Given this list of marker genes PSD4 (NCBI Gene Id 23550), CDC45, CRIM1, ARAP3, PTGFRN, NCKAP5, CPNE1, MYBPC2, DDOST, PSMB2, HNRNPA1, ROCK1, ZEB2, DUSP2 (NCBI Gene Id 1844), UFD1, ST18, NYAP1, GSE1, TNS2, MRPS18B, RDH10, TAGLN, RORA, SH3KBP1, TSPOAP1, SERTAD3, SPOP, SHC1, RASAL1 (NCBI Gene Id 8437), AUP1, JAKMIP2, LEFTY2, PDGFB, PHF12, ATP6V1E2, SKIDA1, HOXB1, KMT2E, SLC8A3, CHRM1, CNIH2, LINC01138, MEX3B, TSSK3, TINAGL1, RHOG, ELK3, CSRNP2, RPRD2, NSD1, MYL6B, INTS13, IL1RAPL1, FHL3, GDNF, EIF4E, CEP57, TPR, GARNL3, SMYD2, NDUFS4, CACNG6, PSMB1, BCL2, SLC4A2, PAFAH2 (NCBI Gene Id 5051), RHCE, RGL2, LAMB3, PRMT3, SERPINB5, RBM12, MAGED2, DCHS1, DMXL1, BMP4, HPX, RPS14, SKAP1, BCOR (NCBI Gene Id 57686), UBE4B, MIR22HG, POLD4, RPP21 (NCBI Gene Id 95307), S1PR1, DYNC1I1, PHC1, GPR3, THADA, H3-3B, SEMA4A, AJUBA, PTCH1, SGCD, KCNC1, CNOT4, SPTAN1, LCOR, TSPAN18, ZNF462, SRRM1, ELAVL2, IGF2BP3, GRIN2D, GTF2A1, CHRNB2, DDX17, NXPH4, SLC26A9, SOX21, SNX12, FGFR1OP2, ADCY8, ZNF532, HTRA2, NCDN, TARBP2, CSNK1E, SPEM1, EN1, SYVN1, FBXW7, CHD6 (chromodomain helicase DNA binding protein 6), GPRC5D, WDR81, ELN, PSD, HNRNPUL1, ZFHX3, PRX, LAG3, C1orf21, PIK3CG, GRHL3, RIPOR2, MEX3C, PI4KB, EVX1, XPO4, JMJD1C, KCNA1, TWIST1, CREM, NRGN, ATP2B4, ANP32E (acidic nuclear phosphoprotein 32 family member E), TEAD1, C1QTNF5, PIAS3, DUSP5, UBE2E4P, PIK3R1, ZSWIM8, POLG, SLAIN1, TSHZ1, RTCA, DNAJC11, PPP1R10, ARID1A, KCNH2, FOXN3, TBP, MBNL1, RRM1, ARHGDIB, MYO18A, CD68, PRMT1, SLC25A4, VEGFA, PLA2G2F, YBX2, BMF, IGFBP5, STX5, LHX6, CADPS, PPP1R15B, AGPAT4, ZSCAN20, SPEF1 (sperm flagellar 1), DACH2, NRP1, LTBP1, CCAR2, DIO3, ARHGEF19, ODR4, RARA, NFE2, KCNJ5-AS1 (KCNJ5 antisense RNA 1), CCNI, RBMS1, RNF152, SIPA1, SUFU, ONECUT2, NIBAN1, CACNB2, STMN1, CALD1, CBX5, NEUROD1, JADE1 (NCBI Gene Id 79960), LIN28A, KBTBD12, ANKRD35, CKS1B, ZFP91 (NCBI Gene Id 80829), HOXC13, GABRB1, WBP2NL, RIMS1, RUNX2, WT1, LRRTM3, KLK14, RHD, CTDSPL2, ZNF827, EIF4G2, LAMA3, ENTPD1, RAB5C, IRX2-DT, FAM76B, PMEPA1, MYH6, ARID5A, CACNG2, OTX2, TMEM255A, IRX2, CRK, SP3, UBE2Q1, SMARCA1, GLRA1, RNF144B, KCNQ5, SNPH, ACTR1A, RPL7, ZNF362, LEFTY1, SMG1 (SMG1 nonsense mediated mRNA decay associated PI3K related kinase), SYT11, GATA1, PIM1, ZNF366, DQX1, KCNN4, NOTCH3, HCLS1, HPCA, UBXN10, ZNF324B, here is a description of the gene set: Genes having at least one occurrence of the motif AGACNBCNN in the regions spanning 4 kb centered on their transcription starting sites. This matches the SMAD1 transcription factor binding site V$SMAD_Q6 (v7.4 TRANSFAC). studied in species Homo sapiens Human Gene Set: SMAD_Q6